The following is a description of a gene set: Human Gene Set: E2F1_Q6_01 Genes having at least one occurrence of the motif NTTTCGCGCS in the regions spanning 4 kb centered on their transcription starting sites. This matches the E2F1 transcription factor binding site V$E2F1_Q6_01 (v7.4 TRANSFAC). studied in species Homo sapiens, and this is the list of marker genes: HR, GPRC5B, CLSPN, KBTBD7, PRPS1, YBX2, PPP1R8, RPS19, RANBP1, TRIM39 (NCBI Gene Id 56658), HCN3 (hyperpolarization activated cyclic nucleotide gated potassium channel 3), ZEB1, CTNND2, TRMT2A, AK2, NPAT, SPHK2, TRMT13, LRTOMT, PCSK1, ERF, TBX6 (T-box transcription factor 6), TNF, FANCC, HNRNPD, FAM120C, MCM2, SUMO1, ZDHHC24, NUMA1, ILF3-DT, LRP1, HNRNPR, PKMYT1, CDC45, SLC25A1, PRPF38A, ERBIN, GADD45B, DHH, CCNT1, GSPT1, FANCG, H2AC12, RAB11B, TRMT6, CASP2, DOLK, ORC1, DDX17, POLR1G, PAN2, NCBP1, RAD51, RBL1, MSH2, CDC5L, MCM6, SASS6, PIK3CD (phosphatidylinositol-4,5-bisphosphate 3-kinase catalytic subunit delta), SYT6, RNF207, PHF13, KMT5A (NCBI Gene Id 387893), MYC, MCM3, SREK1, SYNCRIP, MAZ, CCDC150, HIRA, ZCWPW1, ZNF644, SLC9A5, MEIS2, REPS2, DNAJC5G, FIZ1, ENPP1, UBR7, AP1S1, TMEM108, JADE1, UNG, E2F1, SRSF1, PTMA, ARHGAP6, MGAT2, NASP, ATAD2, USP49, DNAJC9, ATP5MC2, RIBC1, FAF1 (Fas associated factor 1), ANKHD1-EIF4EBP3, GNG4, ZNF367, FBXO5, OTUD7B, CBX5, RPL18, CHD4, ZMYM2, SMARCA1, JADE2, ESPL1 (NCBI Gene Id 9700), MCM7, FZD1, PCIF1, SP1, CPSF7, SMC1A (structural maintenance of chromosomes 1A), CDC25A, PPM1D, POLE2, PPRC1, TMPO, MTSS1, MEPCE, HMGA2 (NCBI Gene Id 8091, high mobility group AT-hook 2), RSBN1, GEN1, TBC1D31, EED, PODN (podocan), AMD1, RAVER1, SMC6, DNAJC11, KIAA0825, AP4M1 (NCBI Gene Id 9179), POU2F1, RB1CC1, MRPL40, CADM2, FLI1, STT3B, DDB2, JPH1, PAQR4, UXT, HOXC10, SIK2, IRX3, HNRNPA1, ANKHD1, TSTD2, ASXL2, USP37, ZNF362, CNOT3, SRSF2, CDCA7, MCM8, STAG2, MTF2, TFAP4, E2F8, TMEM143, CTDSPL2, KCNS2, ATAD5, SYNGR4, MCMBP, ILF3, GATA1, STMN1, SERBP1, SDHAF2, NUFIP2, BMP2, DNMT1, PCNA, FKBP5, KANSL1L, TAOK2, UFD1, NIPBL, PAX6, PRKDC, EIF1AX, PLD5, FHOD1, POLA1, MAP4K1 (mitogen-activated protein kinase kinase kinase kinase 1), BRMS1L, ARHGAP11A, ID3, YPEL4, EIF3K, GON7, USP2, ATE1, POLD3 (NCBI Gene Id 10714), SUV39H1, ADAMTS2, NCL, INTS7, DLEU2, MXD3, RELT, ACO2, ACTN3, STK35, TYRO3, KLF5, PNPLA6, SLC9A7, HMGN2 (NCBI Gene Id 94860), IPO7, ACBD6, SIN3A, POLA2, TOPBP1 (NCBI Gene Id 11073), WEE1, CTCF, INSM1, DLEU1, HNRNPUL1, EZH2, NCOA6, PHF5A, MYH10, NABP2, STAG1, CNOT9 (NCBI Gene Id 9125), CASP8AP2, E2F3, NOLC1, FXR2, ATM, EFNA5, ZNF524, NSD3, KBTBD6, PCYT2, MCM4, PCDH10, TMEM187 (transmembrane protein 187), H2BC12, GMNN